Given this list of marker genes C1orf21, SCYL1, ZNF280B, ZNF148, KPNB1, SCN5A, GTF2I, MBD2, ADIPOR2, RMND5A, ARHGAP18, ADAMTS15, MIER3, BCL2L11, PALLD, SOCS5, COMMD8 (COMM domain containing 8), FOSL1, MBD6, HS6ST2, ALDH1A2, USH2A, NRBF2, CPT1A, PAIP2B, LCOR, KCNMB4, ANKRD27, ZNF699, BCOR, EML1, REV3L (NCBI Gene Id 7807), SHOX, TEAD1, RFTN1, UBE2H, FLT1, KANSL1L, TRPM4, ITGA6, LIN28B, PMP22, TOP1, LDLRAP1, HADHB, ZFHX3, ZSWIM6, ZNF710, PBX3, ABCC4, IPO9, IGF2BP2, ST13, NEB, FBXO17, ZBTB14, MAP3K7CL, DCSTAMP, NET1, KCTD8, NUBPL, CARF, GSK3B, SNX30, REST, MMD, EOLA1, SPOPL, HLA-DPB1, TPK1, FTSJ1, CALU, ZNF107, SLC22A4, GRIA3, SANBR, ZKSCAN4, KAT6A, HNRNPH3, ATG3, OTX2, ARPC5, KIF24, ZNF384, DCUN1D5, HIPK2, MAP3K20, CDC14A, TOR1AIP1, STRN3, PEX5L, NR2F2, POU2F2, TBC1D8, here is a description of the gene set: from publication Chen Y, Wang X (PMID 31504780) Genes predicted to be targets of miRBase v22 microRNA hsa-miR-5087 in miRDB v6.0 with MirTarget v4 prediction scores > 80 (high confidence targets). studied in species Homo sapiens Human Gene Set: MIR5087